Given this list of marker genes Rinl, Rab7, Rap1b, Rapgef2, Sbf2, Rab5b, Rasef, Eif2b2 (eukaryotic translation initiation factor 2B, subunit 2 beta), Rras, Suclg1 (succinate-CoA ligase, GDP-forming, alpha subunit), Arl3, Srp54a, Gripap1, Gm266, Rgs14, Ankrd27, Dis3 (DIS3 homolog, exosome endoribonuclease and 3'-5' exoribonuclease), Obscn, Rapgef6, Rin1, Eif2b1, Rangrf, Sos1, Dennd2d, Eps8l3, Rit2, Dennd2a, Rasgrp4, Rasgrp2, Rab9b, Itsn2, Srp54b, Gem (GTP binding protein overexpressed in skeletal muscle), Chml, Ric1 (RAB6A GEF complex partner 1), Vav2, Dennd1a, Dennd2c, Wdr41, Rab3il1, Arhgef16, Lamtor2, Rhebl1, Ccz1, Arhgef28, Dock6, Arhgdig, Rap2b, Bcar3, Egf, Rab14, Kndc1, Diras2, Rheb, Rcc1l, Arhgef38, Rhob, Ngef (neuronal guanine nucleotide exchange factor), Dennd10, Rasl12, Lamtor3, Rabgef1, Gnai3, Eras, Farp1, Dock9, Rasgrf2, Dock8, Tiam1, Rab12, Gdi2, Nme2 (NCBI Gene Id 18103), Diras1, Ralgds, Dennd11, Psd4, Abr, Sos2 (SOS Ras/Rho guanine nucleotide exchange factor 2), Lamtor4, Kras, Iqsec3, Arhgef11, Arhgef37, Dock7, Tbc1d10a (TBC1 domain family, member 10a), Nucb2, Sbf1, Chrm4, Psd, Ucp2, Akap13, Arf6, Plekhg2, Dync1li1, Itsn1, Rcc2, Rhoa, Rapgefl1, Gpsm1 (NCBI Gene Id 99317), Mief1, Plcg1, Rapgef5, Arhgef19, Ucp1, Gpsm2, Dennd1c, Mcf2l, Prps2, Rcc1, Arhgef40, Arhgef15, Gbp2, Arhgef39, Rasgef1c, Preb, Arhgef12, Arhgef10l, Farp2, Dennd4a, Gapvd1, Dennd6a (DENN domain containing 6A), Rasgrp3, Fgd1, Ccdc88c, Arfgef3, Rab5a, Thg1l, Rap2c, Arhgef4, Eif2b3, Slc38a9, Rab40c, Gnai1, Rab9, Hps4, C9orf72, Rgl1 (ral guanine nucleotide dissociation stimulator,-like 1), Eps8l2, Smcr8, Srp54c, Dennd4c, Lamtor5, Rab8a, Dennd5b, Trim23, Psd3, Rabif, Rab2a, Eps8l1, Rragc, Arhgef9, Rab10 (RAB10, member RAS oncogene family), Arhgef6, Plcd4, Ric8b, Rab18, Madd, Arl8b, Fgd2 (NCBI Gene Id 26382), Dennd1b, Rapgef3, Sh3bp4, Dock10, Rab3gap1, Iqsec1, Arfgef2, Arhgef5, Rab11b, Vps9d1, Hps1, Cyth2, Rap1gds1, Hras, Spata13, Fgd4, Kalrn, Rab28, Plekhg5, Vav3, Fgd5, Tiam2, Arhgef7, Pcp2, Iigp1, Arhgef2, Fgd3, Dock11, Pck1, Plekhg3, Cyth4, Dnm1, Eef1b2, Mcf2, Arhgef33, Elmo1, Chm, Net1, Mon1a, Frmd7, Arhgef18, Sergef, Rasgef1b, Cyth3, Arhgdib, Vav1, Rgl2, Ran, Ric8a, Dock4, Als2cl, Rab35, Rapgef1, Rragd, Fbxo8, Dock5, Rala, Prex2, Prex1, Dock1, Rab21, Eif5, Dennd3, Psd2, Ccdc88a, Cyth1, Rasgrf1, Tagap, Mycbp2, Rap1a, Ngb, Rab8b, Dennd2b, Dennd5a, Septin5, Rgp1, Iqsec2, Rab27b, Arhgef17, Gbf1, Prps1, Dock3 (dedicator of cyto-kinesis 3), Rab4a, Plekhg1, Arf1, Dennd4b, Ect2, Rras2, Lamtor1, Ranbp10, Plce1, Rab3gap2, Fgd6, Rab3ip, Rab31, Rpgr, Rasgrp1, Gbp2b, Arfgef1, Nucb1, Arhgef10, Arhgef25, Rapgef4, Arhgef3 (Rho guanine nucleotide exchange factor 3), Eif2b4, Arhgdia, Rab5c, Dnmbp, Dennd6b, Rab17, Rab3b, Eif2b5 (NCBI Gene Id 98024), Mras, Ralgps2, Als2, Sh3bp5, Suclg2, Rab27a, Bcr, Ralb, Trio, Rit1, Rerg, Plekhg6, Rab29, Ralgps1, Rgl3, Deptor, Gdpgp1, Sh3bp5l, Rab22a, Rap2a, Sesn2, Sec61b, Eef1d, Itgb1bp1 (integrin beta 1 binding protein 1), Rasgef1a, Sh2d3c, Dock2, Rin3 (NCBI Gene Id 97835), Gdi1, Nras, Arhgef1, Rin2, Arl2, here is a description of the gene set: Binding to GDP, guanosine 5'-diphosphate. Mouse Gene Set: GOMF_GDP_BINDING studied in species Mus musculus